The following is a description of a gene set: from publication Dorn A, Zhao H, Granberg F, Hösel M, Webb D, Svensson C, Pettersson U, Doerfler W (PMID 15681441) species: Homo sapiens The infection of human cells by adenoviruses leads to a gradual reduction in the activity of host cell functions while viral gene expression progresses in a regulated way. We used the DNA microarray technique to determine the transcriptional activity profiles of cellular genes upon infection with adenovirus type 12 (Ad12). The microarray data were validated by quantitative real-time PCR for genes which showed significant alterations after Ad12 infection. At 12 h postinfection, there is a striking up-regulation between 10- and 30-fold in the expression of the G1P2, IFIT1, and IFIT2 cellular immune response genes compared to mock-infected cells. At later stages of infection, when the majority of regulated cellular genes has been turned down, a limited number of cellular genes exhibit increased activities by factors of 3 or less. These genes belong to the signal transduction or transcriptional regulator classes or are active in protein degradation, like ANPEP, an aminopeptidase. The SCD and CYP2S1 genes function in lipid metabolism. The eucaryotic translation initiation factor 4 is up-regulated, and one of the major histocompatibility complex genes is diminished in activity. For two of the genes, one up-regulated (CTSF gene) and one down-regulated (CYR61 gene), alterations in gene activity were confirmed at the protein level by Western blotting experiments. Increased genetic activity of cellular genes late in adenovirus infection has not been reported previously and demonstrates that Ad12 has a sustained control of host cell gene expression well into the late phase of infection. Human Gene Set: DORN_ADENOVIRUS_INFECTION_48HR_UP Genes up-regulated in HeLa cells (cervical carcinoma) 48 h after infection with adenovirus Ad12., and this is the list of marker genes: TSC22D3, SH3BP5, BACE2, H2BC12, ANPEP, FUBP3, PDE2A, RASL12, MYC (NCBI Gene Id 731404), ELF3, NFKB2, ATF4, IFIT2, TOP2A